Given this list of marker genes EN1, WNT3, TAF1, RAD1, RHOA, FZD3, FGFR1, YWHAQ, RAC1, CSNK1D, UCHL5, CCDC14, FZD1, G6PD (NCBI Gene Id 83159), LMX1A, CNP, INA, KAT2A, CKB, MSX1, CMA1, YWHAH, BARHL1, TTBK1, FZD6, PITX3, H2BC12L, SYPL2 (NCBI Gene Id 284612), PLP1, CDC42, SFRP1, LRP6, NDST1, FGF2, KDM2B, DYNLL1, ZNF430, GLUD1, OTX1, HES1, SUDS3, CALM1, BASP1, MAPKAP1, HSPA5, SYNGR3, SEC16A, WNT9B, FOXB1, SOS1, NDRG2, NR4A2, DKK1, WNT1, PHOX2A, YWHAE, SIRT2, NDUFS3, OTX2, WLS, SFRP2, DLG5, ATP5PB, S100A1, COX6B1, CALM2, SMAD1, TAL2, ACTB, MAG, CASP5, MBP, CTNNB1, POTEE, KDM7A, CALM3 (calmodulin 3), WNT2, FGFR2, ZNF148, ATP5PF, LDHA, FGF9, GDF7, GNB4, WNT5A, UQCRQ, RYK, EN2, PADI2, TFAP2D, WNT3A, SHH, MAOB, here is a description of the gene set: species: Homo sapiens The process whose specific outcome is the progression of the midbrain over time, from its formation to the mature structure. The midbrain is the middle division of the three primary divisions of the developing chordate brain or the corresponding part of the adult brain (in vertebrates, includes a ventral part containing the cerebral peduncles and a dorsal tectum containing the corpora quadrigemina and that surrounds the aqueduct of Sylvius connecting the third and fourth ventricles). Human Gene Set: GOBP_MIDBRAIN_DEVELOPMENT